Given this list of marker genes Cul1, Irak1, Lrrc14, Casp8, Psmd7, Nlrc5, Tab3 (NCBI Gene Id 66724), Peli2, Psmc3, Psmc5, Nfkbia, Psmd12 (NCBI Gene Id 66997), Psmb5, Nfkb2, Nlrx1, Ube2n, Nfkb1, Map2k6, Tifa, Hmgb1, Psma5, Myd88, Psma2, Psmb4, Nkiras1, Map3k3, Psmc1, Psmb6, Psmd13, Psma6, Psma1, Rela, Ubb, Map3k8, Ager (advanced glycosylation end product-specific receptor), Psmd6, Sqstm1, Psmc4, Tab1, Il1a, Irak3, Psmc2, Ube2v1, Psma4 (NCBI Gene Id 26441), Psmb7, Psmd1, Il1r1, Rps27a, Psma7, Nfkbib, S100b, Il1r2, Psma3, Ikbkb, Psmc6, Tab2, here is a description of the gene set: Reactome Pathway: Interleukin-1 signaling This event has been computationally inferred from an event that has been demonstrated in another species.<p>The inference is based on the homology mapping from PANTHER. Briefly, reactions for which all involved PhysicalEntities (in input, output and catalyst) have a mapped orthologue/paralogue (for complexes at least 75% of components must have a mapping) are inferred to the other species. electronically inferred by orthology from the curated human pathway part of: Interleukin-1 family signaling studied in species Mus musculus